The following is a description of a gene set: Human Gene Set: GOBP_REGULATION_OF_NEUROTRANSMITTER_SECRETION Any process that modulates the frequency, rate or extent of the regulated release of a neurotransmitter from a cell. species: Homo sapiens, and this is the list of marker genes: RAP1BL, FMR1, NPY, MYOF, SYT8, SYT4, CACNA1B, CAMK2A, SYT13, PPFIA2, PFN2, STX1B, GGCX, CPLX4, KMO, SYN1, BGLAP, DYSF (dysferlin), CDK5, PPP3CA, RAB5A, PREPL, SLC30A1, SNCA, NLGN1 (NCBI Gene Id 22871), SV2B, SV2C, RAB3A, FER1L5 (fer-1 like family member 5), MCTP1, PRKN, CACNB4, CHRNA3, GPR151, SNAPIN, LRRK2, ADORA2A, ASIC1, GIT1, STXBP1, FBXL20, RAP1B, SYT1, SLC18A3, BRAF (NCBI Gene Id 673), SYT2, KCNMB4, CALM3, RIMS2, WNT7A, OTOF, SYT5, SEPTIN5, P2RX1, NGF, ATP2A2, FBXO45, GPER1, MCTP2, VPS18, SLC38A2, GPR158, MICU3, HCRT, TACR2, PRKCB, RIMS1, P2RY1, CASK, CSPG5, RIMS4, STXBP5, SYT11, CPLX3, DVL1, SNCAIP, PNKD, PRKCG, SNCG, STX1A, NF1, TSPOAP1, MEF2C, RAP1A, RAB3GAP1, BAIAP3, DTNBP1, SLC4A8, CHRNB4, RIMS3